Given this list of marker genes Il6st, Dusp1, Rigi, Tgif1, Nfat5, Cflar, Icam1, Bcl6, Cd80, Irf1, Ptgs2, Il7r, Tap1, Ifit2, Dusp5, Il18, Snn, Ccn1, Sat1, Kynu, Ripk2, Pdlim5, Dnajb4, Tnfsf9, Il1a, Fos, Btg1, Ptpre, Bhlhe40, Ier5, Tnip2, Efna1, Cxcl2, Olr1, Tsc22d1, Plk2, Marcks, Hes1, Slc2a3, Nfkb2, Cxcl11, Gfpt2, Ier3, Smad3, Nfil3, Zfp36, Ldlr (low density lipoprotein receptor), Tnf, F2rl1, Cxcl5, Rela, Ifngr2, Abca1 (ATP-binding cassette, sub-family A member 1), Edn1, Nr4a3, Jag1, Tnip1, Ccrl2, Fut4 (fucosyltransferase 4), Lif, Cxcl1, Areg, Rel, Dusp4, Pde4b, Cebpb, Il23a, Serpinb8, Zbtb10, Rnf19b, Sphk1, Ackr3 (NCBI Gene Id 98703), Birc3, Per1, Tank, Jun, Tubb2a, Icosl, Gadd45b, Ccl5, Maff, Tnfaip6, Hbegf, Tnfaip8, Fosb, Yrdc, Atf3, Klf10, Tiparp, Egr2, Ets2, Bcl3, Cdkn1a, Sgk1, Phlda1, Ccnd1, Il15ra, Ehd1, Dram1, Sod2, Msc, Lamb3, Cd44, Plek, Btg2, Egr1 (early growth response 1), Pmepa1, Ccl20, Il1b, Cd83, Birc2, Relb, Tnfrsf9, Gch1, Gpr183, Kdm6b, Egr3, Pfkfb3, Ifih1, Csf2, Klf2, Serpinb2, Nfkb1, Clcf1, Cebpd, Tnc, Eif1, Inhba, Nr4a1, Ninj1, Dusp2, Mxd1, B4galt5, Cxcl10, Pnrc1, Id2, Nampt, Ccnl1, Trip10, Rcan1, Fosl2, Tlr2, Gem, Myc, Nfe2l2, Plaur, Bcl2a1d, Sdc4, Tnfaip2, Klf4, F3, Spsb1, Zc3h12a, Slc2a6, Gadd45a (NCBI Gene Id 13197), B4galt1, Il6, Nr4a2, Plpp3, Trib1, Panx1 (pannexin 1, NCBI Gene Id 55991), Csf1, Rhob, Btg3, Klf6, G0s2, Bmp2, Map3k8, Stat5a, Nfkbie, Mcl1 (NCBI Gene Id 99928), Plau, Ier2, Cd69, Litaf, Junb, Il12b, Tnfaip3, Klf9, Socs3, Traf1, Irs2, Nfkbia, Vegfa, Atp2b1, Serpine1, Map2k3, Fjx1, Sqstm1, Ptx3, Slc16a6, Ptger4 (NCBI Gene Id 19219), Ppp1r15a, Fosl1, Dennd5a, Phlda2, here is a description of the gene set: Mouse Gene Set: HALLMARK_TNFA_SIGNALING_VIA_NFKB studied in species Mus musculus Mouse genes annotated to HALLMARK_TNFA_SIGNALING_VIA_NFKB based on orthology mappings provided by the Alliance Genome Consortium from publication Howe DG, Blake JA, Bradford YM, Bult CJ, Calvi BR, Engel SR, Kadin JA, Kaufman TC, Kishore R, Laulederkind SJF, Lewis SE, Moxon SAT, Richardson JE, Smith C (PMID 30224793)